Given this list of marker genes Prkar2a, Prkab2, Prkab1, Prkag1, Prkaa1, Prkag2, Sesn2, Prkar1a, Prkag3, Prkaa2, Prkaca, here is a description of the gene set: A protein complex that possesses nucleotide-dependent protein kinase activity. The nucleotide can be AMP (in S. pombe and human) or ADP (in S. cerevisiae). studied in species Mus musculus Mouse Gene Set: GOCC_NUCLEOTIDE_ACTIVATED_PROTEIN_KINASE_COMPLEX